Given this list of marker genes Abcb1a, Rela, Cd38, Ccl2, Adh1, Wbp2, Vps54, Hspa8, Tyms, Ncoa1, Yap1, Gabrb1, Errfi1, Src, Fosb, Trerf1, Abhd2, Gjb2, Nkx2-2, Srebf1, Tgfb2, Acod1, Sox10, Cav1, Fos, Ncoa2, Cyp1b1, Gad2, Tgfb3, Oxt, Cldn4, Dsg2, Gpi1, Oxtr, Txnip, Mbp, Ptger2, Tgfb1, Nr1h3, Tacr1, Fosl1, Tspo, Ube3a (NCBI Gene Id 76097), Csn1s1, here is a description of the gene set: Any process that results in a change in state or activity of a cell or an organism (in terms of movement, secretion, enzyme production, gene expression, etc.) as a result of a progesterone stimulus. studied in species Mus musculus Mouse Gene Set: GOBP_RESPONSE_TO_PROGESTERONE